Given this list of marker genes MAMLD1, SLC39A3, TMEM39A, FAM181A, PSMA6, SLC7A3, NUBP1, IL12B, SPTBN4, EPB41L4A, RNF24, SHC4, ING1, NECAP1, TIMM10, ABTB3, IGFBPL1, TNIP1, ADM, MEP1A, TMEM131L, PPT2, NINL, NFKBIZ, CLDN14, DUSP1, PDZK1 (NCBI Gene Id 96133), WNT1, CTPS1, RAPGEFL1, WDR33, MAB21L2, ASAP3, ATP8B1, LCP1, BRSK2, ADAM21, RAB43, TRAF3IP2, COX17, KLHDC9, AMELX, OPRM1, STMN2, POMGNT2, TRPM5, PSMD11, ACVR1C, NFKBIL1, CSPG5, NPR2, SLC15A3, SLC43A3, PLK3 (NCBI Gene Id 1263), PROX2, NDUFB3, STK40, AGTR2, SEMA6D, TBX15, TNFSF11, ASXL1, ZSCAN20, NEURL2, SLC15A1, RABGGTB, ELOVL3, CTLA4, STAP1, SYNGR3, HNF1B, MYB, TNFSF9, PLXNC1, MYC, LEP, IFITM5, EBF3, WDR59, CD80, TBX4, RASL10B, DENR, NES, ANKRD33B, CD70, KCTD20, LAD1, MLLT11, CALB2, TMEM87A, SGCA, MGAT5, GRK3, CCL5 (NCBI Gene Id 8147), FGF8, MREG, ST8SIA6, LENG9, IL10, PFKFB1, HOXB13, CCND2, LRRC18, EIF4G2, FCRL1, PEA15, DUSP8, PLXND1, CYP4B1, UBE2B, MYL9, REPIN1, DEPDC5 (NCBI Gene Id 9681), SNAI2, EBI3, ATXN1, ANGPT4, HIP1R, MS4A18, TLCD1, PPP1R14A, ZC2HC1C, OTUD1, CD72, TIMM8A, RBM44, TFEB, DUSP14, CAVIN4, TSPYL5, FXYD7, NPHS1, MATCAP1, TET2, COL10A1, ODC1, RGMA, CRACD, CHRNA4, HRH1, TUBB6, LOXL1, SUB1, UGCG, TMCC3 (NCBI Gene Id 57458), JPH2, MROH2B, TP53INP2 (tumor protein p53 inducible nuclear protein 2), YAE1, ASPA, LEPR, DPF1, ATP13A3, IL4I1, MPZ, PPM1L, BCL2L1, SOCS3, IGF2BP2, COLGALT1, BAIAP3, MRPS10, ICOS, GPR161, OR51E1, PTCD2, PRKAG3, IL31, HAUS8, XPNPEP2, SNX31, ADRB1, CCL1, PRAMEF2, ACSL6, HIVEP3, PUM3, TNNI1, KRTAP19-3, MFHAS1, DTX2, ZNF475, YBX2, TSPAN6, LMNTD1, IL6 (NCBI Gene Id 3569), SYCE1, UBD, WDR1, CYP8B1, MAFF, PCDHB15, AQP6, RHBDL3, PSTPIP2, NKX3-1, CEACAM21, EEF1E1, S1PR3, here is a description of the gene set: from publication Ochiai K, Maienschein-Cline M, Simonetti G, Chen J, Rosenthal R, Brink R, Chong AS, Klein U, Dinner AR, Singh H, Sciammas R (PMID 23684984) Human Gene Set: GSE46606_DAY1_VS_DAY3_CD40L_IL2_IL5_STIMULATED_IRF4MID_BCELL_UP Temporal analysis of B cell activation in vitro using CD40L and IL-2/4/5 cytokines in wild type Irf4+/+ B cells or in mutant Irf4-/- B cells harboring a tet-inducible allele of Irf4. IRF4 expression was restored, or not, in the Irf4-/- background by culturing in the presence of low or high concentrations of doxycycline. The results provide insight in the role of IRF4 expression levels in coordinating different programs of B cell differentiation. studied in species Homo sapiens Genes up-regulated in CD40L and IL-2 IL-4 IL-5 stimulated at day 1 B cell IRF4intermediate versus CD40L and IL-2 IL-4 IL-5 stimulated at day 3 B cell IRF4intermediate.